The following is a description of a gene set: Mouse Gene Set: TABULA_MURIS_SENIS_MESENTERIC_ADIPOSE_TISSUE_MYELOID_CELL_AGEING studied in species Mus musculus from publication Tabula Muris Consortium (PMID 32669714), and this is the list of marker genes: Kdm6b, Dcn, Akt1, Sparc, Cfl1, Tle5, Ptp4a2, Mgp, Rpl13a, Cotl1, Pcnp, Krt14, Capza1, Gstm1, Tmem263